Given this list of marker genes EOGT, F13A1, TRIP6, CSTA, SLC19A1, CCL19, TBXAS1, PRKCB, TNFSF13, CCL17, PDGFC, BLNK (NCBI Gene Id 29760), TNFRSF4, ZNF185, PLXND1, ASAP1, TMEM176B, NFKBIE (NCBI Gene Id 4794), CLIC2, RAP2B, WLS, PLXNB2, MBNL3, LAIR1, MS4A4A, PTGS1, IGSF6, SERPINF1, ATF5, TNFRSF11B, RPGRIP1, CREG1, AP1B1, MAN2B1 (NCBI Gene Id 4125), TRIB1, STEAP3 (NCBI Gene Id 55240), TNFAIP2, DAPK1, HCK, LAMP2, FIG4, AHCY, IL1R2, HLA-DMB, SQLE, MCM3AP-AS1, GAA, ATP6V0C, MMD, MAFK, PLK2, MSRA, TCF4, CCL23, GP1BA, YBX3, LRRC42, CYREN, NPL, CD209, CHN2, GADD45A, ATRN, GPR35, TREM2 (triggering receptor expressed on myeloid cells 2), GPX4, CFP, LAMC1, SYT17, MARCKSL1, DYSF, BID, KCTD3, PLOD1, DSC2, HLA-DQB1, IRGQ (immunity related GTPase Q), SYNGR2, CARD9 (caspase recruitment domain family member 9), SPRED2, CD81, TSPAN4, SELENOP, MARCKS, SOCS2, EHD4 (EH domain containing 4), FADS1, NAGA, RAMP1, TCEAL4, NEU1 (neuraminidase 1), ICAM4, MCOLN1, TPM2, FSCN1, PLAAT3, SCRN3, CAMKK2, AOC1, EIF4G3, SH2B3, GRK3, FUCA1 (NCBI Gene Id 2517, alpha-L-fucosidase 1), ALOX15B, HNMT, GSTP1, CD86, RNASE1, GNA15, NPC2, RASSF4, CD68, LYPD3, CTSA, HSD17B14, LILRB1, CCL24, BMAL2, PLCG2, ALOX5, TNFRSF9, MGLL, HEATR6, BLVRB, HLA-DPB1, MAOA, BASP1, TBC1D8, QPRT, LMNA, CD1C, PLA2G7, IL21R, DSC1, PILRA, MRC1, SGPL1, MILR1, HLX, NINJ1, RAB32, NT5DC2, CD302, CAPG, TRDMT1, CSF1R, CST3, EBI3, ITSN1, IFNGR1 (interferon gamma receptor 1), BMP2K, CCL13, SLC2A8 (NCBI Gene Id 29988), IL13RA1, CLCA3P, PIEZO2, RASSF2, IL1R1, ATOX1, PSG6, METTL1, CD83, RAB20, NAIP, SIRPA, ZMIZ1, OLFML2B, FAH, CYP27A1, WNT5B, C1S, CCL18, FDXR, EFHD2, FADS2, MYO5A, GAS6, SIAH1, SNX2, SMS, VAT1, ARHGAP22, FTL, SLCO2B1, YWHAH, LIMCH1, TUBB6, NFIL3, GTSE1, TMEM97, HLA-DQA1, SFN, POR, DPYSL2, ALOX15, EPB41L2, CCDC28B, CPVL, LGMN, TMEM176A, here is a description of the gene set: studied in species Homo sapiens from publication Prots I, Skapenko A, Lipsky PE, Schulze-Koops H (PMID 21347372) Genes up-regulated in comparison of CD25- T cells treated with IL4 at day 5 versus untreated CD25- T cells at day 5. Human Gene Set: GSE24634_IL4_VS_CTRL_TREATED_NAIVE_CD4_TCELL_DAY5_UP CD25+ regulatory T cells develop in the thymus (nTregs), but may also be generated in the periphery upon stimulation of naive CD4 T cells under appropriate conditions (iTregs). The mechanisms that regulate the generation of peripheral iTregs are largely unknown. We used microarrays to gain insights into the molecular program of extrathymic Treg development.